The following is a description of a gene set: Genes down-regulated in spleen CD8- dendritic cells versus bone marrow monocytes. studied in species Homo sapiens To understand the functional relationship between brain dendritic cells (brain DCs) and other myeloid cells, we compared the gene expression profile of m/chDCs to that of bone marrow monocytes, brain microglia and classical spleen CD8+ and CD8- DCs. In order to obtain enough brain DCs for mRNA extraction, we expanded brain DCs with in vivo Flt3L treatment before purification. from publication Anandasabapathy N, Victora GD, Meredith M, Feder R, Dong B, Kluger C, Yao K, Dustin ML, Nussenzweig MC, Steinman RM, Liu K (PMID 21788405) Human Gene Set: GSE29949_CD8_NEG_DC_SPLEEN_VS_MONOCYTE_BONE_MARROW_DN, and this is the list of marker genes: DEFA6, PPFIA2, HLA-DQB1, ANGPT2, SPTBN1, NPC1, PPFIBP1, KRT12 (keratin 12), ZRSR2, DMXL1, PITX2, IL1R2, RBM8A, ACADL, TOM1, COG4, CREB3, XCL1, FBLN1, DNAJC11, VAMP4, KYAT3, CCN6, CP, KCND3, NKG7, CASP8, PRLR, GAPDH, LCT, SULT4A1, KAT2B, ADM, BCKDK, SERPINB2, SLC4A2, PSMB4, GNA15, ALOX12, ELP4, SREK1IP1, INHBA (inhibin subunit beta A), ST8SIA4, HTR2A, PECAM1, MIA, CRADD, RAB30, CEP43, CDIPT, NELL1, PAX1, LRRC41, NINJ1, CABP1, PHTF1, TBP, RAD52, L3MBTL1, CALCOCO1, SLC6A9, PTHLH, TAF6L, PRL, PFKFB4, HERC2P3, ALG3, MAGEA5P, EIF4G1, KRT5 (NCBI Gene Id 3852), RAP2A, CYP1A1, BMP3, MTCP1, KAT5, NOC2L, TPST2, EXT1, FZD7, GZMB, RGR, MYH10, SMNDC1, CLCN5, PHACTR4, ABCC6, ENTREP2, ST8SIA1, OR2H1 (NCBI Gene Id 81408), MMP10, CERNA1, PXDC1 (PX domain containing 1), YWHAE, GCLM, PIGA, MT1B, RNF13, MICAL2, CD5, CD28, CHST2, NUBP1, MT1H, SENP3, MSL3, EDNRA, GRK5, SERPINB1, AMOTL2, BCAS2, CST7, PEX3, NELFA, TUFM, XPNPEP1, TRIP10, ARPC1A, PSD4, IL33, ELMO1, INSIG2, LRRC32, TES, STC1, YIF1A, BUB1, IDUA, SPRY1, SUPT4H1, PARVA, PCYT1A (NCBI Gene Id 5130), FAM161A, GIGYF2, NDRG4, DLGAP1, RING1, RPE, SEC24A (NCBI Gene Id 10802), HPCAL1, IMPG1, ANKRD7, TSC1, ALDH1L1, IRF2, ARG1, RAD51C, PAN2 (poly(A) specific ribonuclease subunit PAN2), UBR5, N4BP2L2-IT2, CACNB4, SLC4A4, ANKRD6, NFIL3, APBB3, NDST2, CAMKK2, CD38, IL7R, IGHM, MAFF, CBLIF, TBL1X, COL8A1, SSB, TACR3, BAG2 (BAG cochaperone 2), ZNF548, ANXA13 (NCBI Gene Id 312), JUND, LDLRAD4, ETFDH, AKR1C3, BBOX1, PRPF18, SIGLEC7, FRMD4B, AK4 (adenylate kinase 4), ZNF415, ABCC1, ZNF175 (NCBI Gene Id 7728), KIAA0753, ODF1, BNIP3, SEC31B, BCL6, SLC16A3, PRKCB, SLC18A2, EFNA1 (ephrin A1), ERCC1, CD99, MC2R, RENBP, FOXO3, HAAO, FHIT